The following is a description of a gene set: studied in species Homo sapiens Genes predicted to be targets of miRBase v22 microRNA hsa-miR-3678-3p in miRDB v6.0 with MirTarget v4 prediction scores > 80 (high confidence targets). from publication Chen Y, Wang X (PMID 31504780) Human Gene Set: MIR3678_3P, and this is the list of marker genes: ONECUT2, RPS6KA6, NBEAL1, MYH10, COL5A2, SLC16A6, ZNF135, AMPH, CYP4Z1, FOXN3, TRIM52, MMP16, AR (NCBI Gene Id 367), ANKRD53, FNDC1, STIM2, SFRP1, MRPS21, TNIK, GGCX, DOK5 (docking protein 5), MS4A7, MMP13, SHANK2, RC3H1, UBB, ITPR1, SRXN1, C9orf152, KCNE4, ZNF385B, TWIST1, ERBB4, TRIQK, DYRK2 (NCBI Gene Id 8445), SSBP2, OPRM1, PPM1E, PHKG2, ALOX12, NFYB, RAB1A (NCBI Gene Id 5861), EDEM3, SLC19A2, CFAP221, LAMA4, BTBD8 (NCBI Gene Id 284697), BTRC, CYP7B1, GAPVD1, RND3, SLC6A11, POLE4, ZNF831, HYCC2, TMEM35A, S100A14, LYSMD4, ATP2A2, PPP1R3D, MED13L, NLRP1, ARL13B, LDLRAD3, PLP2, SSX5 (NCBI Gene Id 6758), RAB10, TNRC6B, ID4, MLLT3, BPIFB1, TMEM98, XPO1, GABBR2, ZFAND6, SBNO1 (strawberry notch homolog 1), ZFP1, SLC39A8, APBA1, ETV1, PRTG, ARGLU1, GRIPAP1, CNTN4, TMEM127, GRIN3A (glutamate ionotropic receptor NMDA type subunit 3A), PANK2, YES1, LTBP1, RTN1, ABLIM1, MSI2, GLRA1, RFTN2, KHDRBS1, CAMK1D, AAK1, GTF3C4, COPS3, SVIP, TLDC2, GNAS, FAM120A2P, TRIM48, STYX, ST3GAL1, GPATCH2L, WASF3, PDS5B, OCLN, NOVA1, KIF11, GIGYF2, ZIC3, GPR158, CDH17, LRRN1, PCNA, SEMA5A (NCBI Gene Id 9037), NHERF2, PRXL2B, PRRT2, AGO1, CDK14, UNG, BHLHE22, RNF215